Given this list of marker genes Psmb7, Psmc6, Psmd7, Gata1, Psmc3, Psma4, Psmb1, Psmd13, Psmd2, Psmb6 (proteasome (prosome, macropain) subunit, beta type 6), Adrm1, Mnat1, Psmd14 (NCBI Gene Id 98839), Psmb5, Tcf3, Psmb3, Lmo1, Ccnh, Gata3, Ubb, Psma7, Psmd8, Yap1, Psmc5, Psmd12, Rps27a, Psma1, Psmc4, Uba52, Psmc1, Psmd1, Tcf12 (NCBI Gene Id 319985), Ldb1, Psma2, Itch, Cdk7, Psmd11, Lmo2, Psmb4, Tal1, Psmc2, Psmd3, Abl1, Gata2, Uba52rt, Trp73, Ubc, Psma3, Kmt2a, Psma5, Psma6, Cbfb, Psmb2, Psmd6, here is a description of the gene set: species: Mus musculus Mouse Gene Set: REACTOME_RUNX1_REGULATES_TRANSCRIPTION_OF_GENES_INVOLVED_IN_DIFFERENTIATION_OF_HSCS RUNX1 regulates transcription of genes involved in differentiation of HSCs